The following is a description of a gene set: electronically inferred by orthology from the curated human pathway species: Mus musculus part of: Processive synthesis on the C-strand of the telomere This event has been computationally inferred from an event that has been demonstrated in another species.<p>The inference is based on the homology mapping from PANTHER. Briefly, reactions for which all involved PhysicalEntities (in input, output and catalyst) have a mapped orthologue/paralogue (for complexes at least 75% of components must have a mapping) are inferred to the other species. Reactome Pathway: Removal of the Flap Intermediate from the C-strand, and this is the list of marker genes: Terf1, Pold2, Pold1, Pcna, Rpa1, Wrn, Pold4, Dna2, Acd, Terf2